The following is a description of a gene set: from publication Yao MW, Lim H, Schust DJ, Choe SE, Farago A, Ding Y, Michaud S, Church GM, Maas RL (PMID 12554760) Human infertility and recurrent pregnancy loss caused by implantation defects are poorly understood. Hoxa-10-deficient female mice have severe infertility and recurrent pregnancy loss due to defective uterine implantation. Gene expression profiling experiments reveal that Hoxa-10 is an important regulator of two critical events in implantation: stromal cell proliferation and local immunosuppression. At the time of implantation, Hoxa-10 mediates the progesterone-stimulated proliferation of uterine stromal cells. Hoxa-10 mutants express a stromal cell proliferation defect that is accompanied by quantitative or spatial alterations in the expression of two cyclin-dependent kinase inhibitor genes, p57 and p15. Hoxa-10 deficiency also leads to a severe local immunological disturbance, characterized by a polyclonal proliferation of T cells, that occurs in place of the normal progesterone-mediated immunosuppression in the periimplantation uterus. Human Gene Set: YAO_HOXA10_TARGETS_VIA_PROGESTERONE_UP Genes up-regulated in the uteri of ovariectomized mice 6 h after progesterone injection: HOXA10 knockout vs wild type animals. species: Mus musculus, and this is the list of marker genes: LEPR, RBP1, PAGR1, SHD, RNF227, ENPP2, CHERP, FLT1, GSTT1, CLDN5, XDH, GAS6, INMT, THRSP, CDH16, CYP2F1, SCD, SERTAD1, SLC25A48, ADIPOQ, CSF3R, GDPD3, TNXB, HLA-DQB1, USE1, KCNAB1, RARRES2, BCL2, ATP1A2, LAMA2, DBP, NR4A1, ID1, PROS1, LTF, RNASE4, HMGCR (NCBI Gene Id 3156), CDKN1C, DDX50, MEG3, TTC14, AQP1, SLC27A1, TRGC1, ARL4A, NDRG2, ELN, KLF9, PIK3R1, REG3A, AKAP8L (A-kinase anchoring protein 8 like), ME1, WNT4, ADM, IDH2 (isocitrate dehydrogenase (NADP(+)) 2), KLF10, PBX3, DTD2, PEG3, CA3, PDPN, TBX3, LCN2, PRPF39, IGLV1-50, CES2 (carboxylesterase 2), REM1, CAVIN2, NCAM1, CFD, ACTB, TNS2, APOE, THBD, GEM, CRIP2, SENP6, NBL1, MEIS1, IGHG1, KLK1, IGFBP3, CYP2E1, B3GALNT1